Given this list of marker genes Mbnl1, Nrf1, Zfp976, Spry2, Ube2d2a, Zmynd19, Dpm2, Zfp810, Fndc3b, Colec10, Ralgapb (Ral GTPase activating protein, beta subunit (non-catalytic)), Cdc40, Cdc42bpg, Chsy3, Cdc7, Ccr9, Cpeb1, Sarnp, Gm2042, Ppm1b, Zfp975, Trpc6, Ankib1, Slc7a14, Mecp2, Mr1, Pdzk1ip1, Epm2aip1, Hyal1, Mid1, Sc5d, Cux1, Phc3, Chrna6, Akr1c14, Zfp120, Ap3m1, Spef2, Otof, Lgals3bp, Ppp4r3b, Mc2r, EU599041, Ift56, Enah, Ncbp3, Pxdc1, Clstn1, Zfp936, here is a description of the gene set: from publication Chen Y, Wang X (PMID 31504780) studied in species Mus musculus Mouse Gene Set: MIR_679_5P Genes predicted to be targets of miRBase v22 microRNA mmu_miR_679_5p in miRDB v6.0 with MirTarget v4 prediction scores > 80 (high confidence targets).